Given this list of marker genes NOG, DCHS1, SIX1, PKD2, FGF2, PAX8, IRX1, TFAP2B, LIF, AGTR2, FGF8, HOXD11, WNT11, HS2ST1, ADAMTS16, AGT, WNT6, VEGFA, FGF1, MEF2C, MYC, SHH, HS3ST3B1, PRICKLE1, MAGED1, SIX2, HNF1B, NPNT, LZTS2, SLC22A6, WNT7B (NCBI Gene Id 7477), STAT1 (signal transducer and activator of transcription 1), TTC8, PROM1, CD24, HES5, CTNNB1, KLHL3, SALL1, AQP1, CALB1, CITED1, LHX1, WWTR1, SIX4, SMAD4, BMP4, GDNF, PKD1, HOXB7, WNT2B, GREM1, LGR5, OSR1, TGFB1, ACAT1, UMOD, GZF1, TCF21, SLC22A1, AQP11, PTCH1, TACSTD2, BMP2, C1orf54, GLI3, HES1, GATA3, NOTCH1, EYA1, DLG1, GREB1L (NCBI Gene Id 80000), NOTCH2, IRX3, HEYL, HOXA11, SOX8, PAX2, WNT4, IRX2, WNT1, TMEM59L, CTNNBIP1, BCL2, WNT9B, ILK, GPC3, WT1, SOX9, AHI1, POU3F3, HS3ST3A1, LGR4, WNK4, JAG1, YAP1, LAMA5, FOXD1, PBX1, MTSS1, KIF26B, COL4A1 (collagen type IV alpha 1 chain), DLL1, SMO, here is a description of the gene set: Human Gene Set: GOBP_RENAL_TUBULE_DEVELOPMENT The progression of the renal tubule over time from its formation to the mature form. A renal tubule is a tube that filters, re-absorbs and secretes substances to rid an organism of waste and to play a role in fluid homeostasis. studied in species Homo sapiens